The following is a description of a gene set: Human Gene Set: GOBP_TRIGLYCERIDE_STORAGE studied in species Homo sapiens The process of binding or confining any triester of glycerol such that it is separated from other components of a biological system., and this is the list of marker genes: APOC4, PLIN3, PLIN2, PLIN5, FITM2, ABHD5, TREM2, PNPLA2